Given this list of marker genes PNP, DDX41, FCGR2B, SPP1, C2, TLR7, C1S, DNASE1L3, DNASE1, SERPING1, C8A, IRAK1, C1QA (complement C1q A chain), STAT4, FCGR2A, FAS, TREX1, PEPD, CTLA4, IGKC, SAT1, TPP2, C3, SOCS1, DOCK11, C4A, SEMA6B, MASP2, PTPN22, CASP10 (NCBI Gene Id 843), SMPD1, ACP5, IGHG2 (immunoglobulin heavy constant gamma 2 (G2m marker)), FASLG, CFTR, here is a description of the gene set: Human Gene Set: HP_SYSTEMIC_LUPUS_ERYTHEMATOSUS Systemic lupus erythematosus A chronic, relapsing, inflammatory, and often febrile multisystemic disorder of connective tissue, characterized principally by involvement of the skin, joints, kidneys, and serosal membranes. species: Homo sapiens